The following is a description of a gene set: Tumor growth is associated with a profound alteration of myelopoiesis, leading to recruitment of immunosuppressive cells known as myeloid-derived suppressor cells (MDSCs). Analyzing the cytokines affecting myelo-monocytic differentiation produced by various experimental tumors, we found that GM-CSF, G-CSF, and IL-6 allowed a rapid generation of MDSCs from precursors present in mouse and human bone marrow (BM). BM-MDSCs induced by GM-CSF+IL-6 possessed the highest tolerogenic activity, as revealed by the ability to impair the priming of IFN- -producing CD8+ T cells upon in vivo adoptive transfer. Moreover, adoptive transfer of syngeneic, GM-CSF+IL-6-conditioned MDSCs to diabetic mice transplanted with allogeneic pancreatic islets resulted in long term acceptance of the allograft and correction of the diabetic status. Cytokines inducing MDSCs acted on a common molecular pathway. Immunoregulatory activity of both tumor-induced and BM-derived MDSCs was entirely dependent on C/EBP transcription factor, a key component of the emergency myelopoiesis triggered by stress and inflammation. Adoptive transfer of tumor antigen-specific CD8+ T lymphocytes resulted in therapy of established tumors only in mice lacking C/EBP in myeloid compartment. These data unveil another link between inflammation and cancer and identify a novel molecular target to control tumor-induced immune suppression. We used gene expression analysis to identify those factors, secreted by tumor-infiltrating MDSC, which could drive emathopoiesis. Moreover we compare gene expression profile of tumor-induced MDSC, obtained from either the spleen and the tumor infiltrate of tumor bearing mice, and in vitro bone marrow-derived MDSC. Genes up-regulated in CD11b+ cells from spleen of BALB/c mice: healthy versus bearing C26GM colon carcinoma. Human Gene Set: GSE21927_HEALTHY_VS_TUMOROUS_BALBC_MOUSE_MONOCYTE_UP from publication Marigo I, Bosio E, Solito S, Mesa C, Fernandez A, Dolcetti L, Ugel S, Sonda N, Bicciato S, Falisi E, Calabrese F, Basso G, Zanovello P, Cozzi E, Mandruzzato S, Bronte V (PMID 20605485) species: Homo sapiens, and this is the list of marker genes: NCOA6, TGM7, TMPRSS2, DDX3Y, PTPN6, RCOR1, LIM2, PHF8, TMX3, TRAF6, PYGO2, GEMIN5, CRCP, STX6, REG1A, ZNF322P1, BTBD10 (NCBI Gene Id 84280), C1QTNF3, STAG1, C3, PALD1, SLC31A2, TGIF2, C19orf84, ALPK2, ZCCHC2 (NCBI Gene Id 84810), LAT2, DNAJB9, NCOR1, KIFC3, ZNF215, HIPK2, HERC4 (HECT and RLD domain containing E3 ubiquitin protein ligase 4), IQCG, RBM39, AIRE, TOR1AIP2, SLC9B2, OXSR1, SRSF11, RAD54B, ZNF555, LINC01924, RAMP3, HAVCR1, PTGFRN, SLC26A2, RSRC1, LINC00115, SLC46A2, UGDH, ADGB, OST4, TAB2, UTP14A, MRPL1 (NCBI Gene Id 65008), ATAD3C, ISL1, THNSL2, LINC00526, FBXW11, RBM4B, HECTD2, ARL5A (ADP ribosylation factor like GTPase 5A), MSL1, SFMBT2, CDC73, SRSF3, ANKRD60, ZNF252P (NCBI Gene Id 441383), SOCS1, CXCL2, MYH11, MT1H, IFIH1, THAP10 (NCBI Gene Id 56906), GSC2, H1-7, NR4A2, TERF2 (telomeric repeat binding factor 2), PRR3, SPMIP1, DEFB125, ARHGEF10, SUFU, ANKRD39, UBASH3A, NR6A1, PPIH, TRIM58, MEGF9, SON, PPP4R3B, HELQ, WDFY3, SQSTM1, LRRC57, GPATCH4, ZDHHC19, SLK, C1orf43, TUBE1, CBY1, ANKRD27 (ankyrin repeat domain 27), USP18, WDR3, BDH1, ZCCHC7, QTRT2, CCPG1, MTRF1L, FLT1 (fms related receptor tyrosine kinase 1), SIRPA, LINC00158, GLS (NCBI Gene Id 51679), COX10, POP1, MKRN3, BIVM, CREM, MN1, IL20RA, SLC25A39, UBFD1, ARID3A, CSNK2A1, RAB7B, FDFT1, TADA1, FCGBP, JAGN1, PSMB6, FBXO38, MGST3, NCEH1, FAM222A, NAIF1, RMDN2, EMC3, ARHGAP36, LYSMD3, SRBD1, LARP6, BLOC1S5, RGS9BP, C2orf42, ATRN (attractin), STXBP4, ERLEC1, TARBP1, DNAJA2, LCE2B, MBD1, RILPL2, KIF26A, GAN, NFAT5 (nuclear factor of activated T cells 5), TTC33, ZNF260, TBC1D9, IL24, FAM3C, ALOX12P2, ARAP2, KRTAP9-9, SAGE1, TRRAP, LINC00937, SYF2, ODF1, ACIN1, STAU2, DUSP19, UTP15, SZRD1, THAP12, SFI1, INTS8, MGAT4D, SLC41A2, TM2D3, TFB2M, OR10A3, FOXO1, GCGR, KNL1, CDK17, ADAM7, NSMCE3, FKBP9, ATP5PF, DRC7